The following is a description of a gene set: species: Homo sapiens Hypoplasia of the pons Human Gene Set: HP_HYPOPLASIA_OF_THE_PONS Underdevelopment of the pons., and this is the list of marker genes: ATXN8OS, TOE1, FOXH1 (NCBI Gene Id 8928), MAB21L1, RELN, SLC25A46, TSEN54, EIF4A2, RTTN, AHCY, B3GALNT2, TUBA1A, LARGE1, TGIF1, EXOSC8, TUBB2B, VRK1, CASK, CDON, GPHN, TSEN2, POMGNT1, VPS51, PTEN, CRIPTO, EXOSC9 (NCBI Gene Id 5393), SLC5A6, ZIC2, POMT2, CLCN3, FGF8 (fibroblast growth factor 8), TUBB3, TBC1D23, PPIL1, PMM2, POMK, GAS1, DOCK7 (dedicator of cytokinesis 7), PI4KA, NODAL, FKRP, MARS2, ARHGEF2, ZIC1, STUB1 (STIP1 homology and U-box containing protein 1), TRAPPC12 (trafficking protein particle complex subunit 12), RERE, GLI2, EXOSC3, MINPP1, DEPDC5, SEPSECS, DLL1, WNT1, MED23, PRDM13, ATXN2, POGZ, POMT1 (NCBI Gene Id 10585), BRF1, SIX3, ADGRG1, PPP2R1A, ASNS, MACF1, UBE2A, DISP1, AGTPBP1, SHH, ROBO1, PIGS, SMARCA2, TSEN34, GMPPB, ENSG00000288330, DCC, MDH1, PCLO, APC2, PLK4, PI4K2A, ALG3, EXOSC1, PTCH1, ROBO3, EPG5, SETD2, AMPD2, STIL, TSEN15, SNX14